Given this list of marker genes PEX2, YIF1B, PRDX6, MRPS26, CERS6, PSMA4, NUDT2, RRM1, LAS1L, IFRD2, RFC4, COPS3, APIP, PHF23, RBKS, DNLZ, NADK, MRPL22, PCNA, HDLBP, ITFG1, SLC35A4, ATP2A2, RAB7A, METAP2, CLUH, PHB2, TMEM51, DLL3, GPATCH4, CTU2, CEP55, EIF3I, CDKN1A, ADI1, NDUFA8, WDHD1, CPTP, IDH3A, FBXL15, SNRPA1, PIN1, CACNA1C, CIAO2B, PRIM2, ACADS, RPA3, ZMYM1, ERH, NHP2, DNAJC15, USP28, SNHG3, BOP1, SPRYD4, GLMN, CAD, BCKDK, TXNL1, MTOR, PPRC1, ALG8, PMM1, PAOX, MBD3, CNIH4, BSPRY, ANAPC1, MRPL23, ITSN1, ATP5F1E, CLNS1A, BCAT1, PTOV1, FDFT1, TIMM17B, HNRNPA0 (NCBI Gene Id 10949), NELFE, SUB1, NMT1, ITPRID2, NQO1, ACY1, GAP43 (growth associated protein 43), LYPLA2, FDX1, GET3, FAF1, DDB1, PPIA, GATAD1, PMP22, MRPL37, LAGE3, PUM3, AARS1, PDZD11, PGLS, BLMH, CASP4, FBXO6, YBX1, MTHFD1, SLC25A10, EML2, GYPC, FCF1 (NCBI Gene Id 51077), METTL13, UQCR10, POLR1D (NCBI Gene Id 51082), NR4A3, ATP6V0C, NDUFV1, GCSH, CDC34, GNL2, NAA38, GCLM, HINT1, WASHC5, TCERG1 (transcription elongation regulator 1), LRP11, KRR1, TRMT61A, RBMXL1, ZNF768, DUT, MAP2K3 (NCBI Gene Id 92079), SRM, IPO11, CCT7, HSPE1, CYP51A1, CNOT9, TRNT1, SDHC (succinate dehydrogenase complex subunit C), MDH2, NME1, TMEM147, EXO1, HIVEP3, TMEM256, PABPC4, RAD23B, GFOD2, MRPL36, LSM12, CENPH, TBC1D7, TBL3, EIF5B, RPL7L1, HMBS, NTMT1, SUPV3L1, PUS7L, EIF4G1, EIF3B, SQLE, CENPC, PRPF31, UNG, UROD, ZMYND19, TXNDC9, GFUS, WNT10A, CDK2AP1, LZTR1, PRDX1, UQCRQ, SEC61B, ACO1, ALAD, CNDP2, MNAT1, C1orf50, NPM1, CLPP, POLR1G, DBI, LSS, LETM1, NUDT5 (NCBI Gene Id 11164), ZNF35, BZW2, AHCY, GRPEL1, NAT10, FAM98A, UBL5, NDUFB7, ACACA, VCPKMT, SMYD5, EIF3G, ATP5F1A, POLA2, NFS1, here is a description of the gene set: from publication Collison LW, Chaturvedi V, Henderson AL, Giacomin PR, Guy C, Bankoti J, Finkelstein D, Forbes K, Workman CJ, Brown SA, Rehg JE, Jones ML, Ni HT, Artis D, Turk MJ, Vignali DA (PMID 20953201) Human Gene Set: GSE24210_CTRL_VS_IL35_TREATED_TCONV_CD4_TCELL_DN studied in species Homo sapiens Genes down-regulated in T conv cells: control versus treated with IL35. Regulatory T cells (Tregs) play a critical role in the maintenance of immunological self-tolerance. Naïve human or murine T cell treatment with the inhibitory cytokine IL35 induces a regulatory population, termed iTR35, that mediates suppression via IL35, but not IL10 or TGFβ, neither express nor require Foxp3, are strongly suppressive in five in vivo models, and exhibit in vivo stability. Treg-mediated suppression induces iTR35 generation in an IL35- and IL10-dependent manner in vitro, and in inflammatory conditions in vivo in Trichuris-infected intestines and within the tumor microenvironment, where they appear to contribute to the regulatory milieu. iTR35 may constitute a key mediator of infectious tolerance and may contribute to Treg-mediated tumor progression, and ex vivo-generated iTR35 may possess therapeutic utility.